The following is a description of a gene set: species: Mus musculus Genes predicted to be targets of miRBase v22 microRNA mmu_miR_1981_3p in miRDB v6.0 with MirTarget v4 prediction scores > 80 (high confidence targets). from publication Chen Y, Wang X (PMID 31504780) Mouse Gene Set: MIR_1981_3P, and this is the list of marker genes: Faim, Fancl, Slain2 (SLAIN motif family, member 2), Arxes1, Vamp3, Atp13a3, Gabrb3, Prps2, Ppp4c, Sfpq, St6galnac3, Nudt16l1, Peg10, H3f3a, Kif2a, H3f5, Cpeb2, Meis2, Glt8d2, Actr6, Cited2, Serpine1, B3gnt2, Fut2, Ehbp1, Abtb3, Bnc2, Car2, Slc12a5, Nanos1, Frmpd4, Spop (NCBI Gene Id 20747), Grik2, Naa15, Cdh10, Inpp4b, Hnrnpk, Zfp316, Cysltr1, Ate1, Rida, Fam227a, Hnf4g, Tmpo (thymopoietin), Qpct, Dcaf11 (NCBI Gene Id 97916), Stk17b, Ccdc91 (NCBI Gene Id 76620)